The following is a description of a gene set: Genes up-regulated in common lymphoid progenitors versus RAG2 knockout NK cells. Expression profiling of Rag2-deficient Ets1++ and Rag2-deficient Ets1-- mature NK cells and WT bone marrow progenitors, WT T cells, and WT Pro B cells Human Gene Set: GSE37301_COMMON_LYMPHOID_PROGENITOR_VS_RAG2_KO_NK_CELL_UP from publication Ramirez K, Chandler KJ, Spaulding C, Zandi S, Sigvardsson M, Graves BJ, Kee BL (PMID 22608498) studied in species Homo sapiens, and this is the list of marker genes: FAM131B, SEC61A1, TMEM177, MRPL28, TMEM35A, HHAT, ADAM12, GORASP2, GYG1, CTSK, ARHGEF12, CD59, MAP7D3, MBNL2, HOXC13, CASP1, POLRMT, EFHD1, GSTA3, CDK5R1, IFNW1, PGM1, ELSPBP1, SECTM1, CRKL, P4HA2, CRADD, ABCB4, MYDGF (myeloid derived growth factor), TUBB2B, PIGO, RAD1, TXNDC15 (NCBI Gene Id 79770), PTPRT, THEMIS2, PRKAB1, PCDHGA10, KLRG1 (NCBI Gene Id 10219), CPD (carboxypeptidase D), TBL1Y, INPP4A, SNTA1, NXPH4, NOL4, EHBP1, FAM110D, RIBC2, MITF, KNG1, KCNK12, MCF2, TRIB2, KCNV1, TMEM59L, MAEA, NDST3, GIMAP5, ICAM5, ATP2B4, SAG, MMP10, CD247, HNF1B, MAGEC2, HIVEP2, STX11, PORCN, PLPPR1, SEC14L3, CD40LG, SLC22A5, LCOR, ADAP2, LGALS14, KCTD5, SORBS3, AK2, HOXB6, IL18R1, OXT, SYP, GNRHR, SLC36A1, MPZL1, BCAT2, LSM14B, ITGB2, ARR3, DDX31, NUP188, ZNF142, ADRA1B, IFNA14, COLEC12, LPAR1, GDF9, EPS8L2, SLC7A5, CREM, PSG7, EOLA2, EEF1A2, SPART, SLC6A12, HNRNPU, AKAP10, CELP, CEBPD, FYN, LANCL1, ZNF137P, AP3B2, RFPL3, MTCL1, PTPRZ1, NRXN2, PRKD3, IGSF3, NINL, SFXN3, BRF2, SMOX, TBC1D31, PLXNB3, COQ6, MGAT4B, HRH2, SPARCL1, CEMIP, CLDND1, TSBP1, KLHDC8A, ARF3, CPS1-IT1, NKX2-2, RHAG, GRPR, IFNGR1, ATMIN, GPR17, CSH2, AGRP, PYGM, IER3IP1, PLXNC1, DCTN5, RAB8A, CD2, AUTS2, TRPM1, SLC25A46, SPRR1B (NCBI Gene Id 6699), IL12RB2, EIF2AK3, PPIP5K1, SNRPB, CDK5RAP1, COL5A1, CAMSAP2, EMC6, TRHDE, SPRR1A, ADH6, ATAD2B, FLT4, PPP2R3A, NAP1L2, AMD1, HNRNPF, MAPK13, C1QB, LHB, PPFIBP2, PACSIN3, POM121L9P, H3C2, RABGEF1, CCDC15, TRIM29, PSTPIP1, NRIP3, PLEKHF1, POGZ, HBEGF, FUT8, SYNGR3, GNAT3, MAPK14, TATDN2, BEX1, BMAL1, ZBTB16, SLC22A13, VLDLR (very low density lipoprotein receptor), CTNNA1